Given this list of marker genes SPARCL1, CRYAB, CSRP1, DSTN, PLN, CCL2, COX4I2, MT2A (metallothionein 2A), GEM, ID4, LHFPL6, CALD1, MYLK, ZFP36, SYNPO2, CAVIN1, C11orf96, PPP1R12A, ECRG4, MAP1B, RERGL, IGFBP5 (insulin like growth factor binding protein 5), NR2F2, FRZB, HIGD1B, ADIRF, CARMN, CRISPLD2, FLNA, NOTCH3, FILIP1L, IRAG1, TPM1, GGT5, JUNB, NDUFA4L2, SPARC, ARID5B (AT-rich interaction domain 5B), IGFBP7, TAGLN, ATF3, GADD45B, GUCY1A1, SOD3, MYH11, TPM2, RCAN2, ADAMTS1, LMOD1, MYL6, PTP4A3, KANK2, LPP, PPP1R14A, FOS, RGS16, HSPA1A, STEAP4, MCAM, EBF1, MAP3K20, SOCS3, PDGFRB, RGS5, EGR1, PDLIM3, ACTA2, ACTG2, TIMP3, CAVIN3, TGFB1I1, JUN, TNS1, EFHD1, THBS1, CAV1, COL14A1, MYL9, ISYNA1, MFGE8, TINAGL1, PALLD, SEPTIN7, RHOB, MT1M, CNN1, HSPA1B, KLF2, PPP1R12B, TCIM, PLAC9, DEPP1, FHL1, here is a description of the gene set: studied in species Homo sapiens Human Gene Set: DURANTE_ADULT_OLFACTORY_NEUROEPITHELIUM_VASCULAR_SMOOTH_MUSCLE_CELLS from publication Durante MA, Kurtenbach S, Sargi ZB, Harbour JW, Choi R, Kurtenbach S, Goss GM, Matsunami H, Goldstein BJ (PMID 32066986)